The following is a description of a gene set: species: Homo sapiens The series of events in which an oxygen stimulus is received by a cell and converted into a molecular signal. Human Gene Set: GOBP_DETECTION_OF_OXYGEN, and this is the list of marker genes: TGFB3, ENG (endoglin), CYB5R4, SLC11A2, SOD2